The following is a description of a gene set: Catalysis of an oxidation-reduction (redox) reaction in which hydrogen or electrons are transferred from NADH or NADPH and one other donor, and one atom of oxygen is incorporated into one donor. species: Homo sapiens Human Gene Set: GOMF_OXIDOREDUCTASE_ACTIVITY_ACTING_ON_PAIRED_DONORS_WITH_INCORPORATION_OR_REDUCTION_OF_MOLECULAR_OXYGEN_NAD_P_H_AS_ONE_DONOR_AND_INCORPORATION_OF_ONE_ATOM_OF_OXYGEN, and this is the list of marker genes: CYP3A4, CYP4X1, NOS3, CYP27B1, COQ6, AKR1C1, CYP1B1, AKR1C3, NOS2, FMO1, CYP51A1, ESR1, HSP90AA1, CYP26B1, CYP46A1, COQ7, FMO5, NOS1, MICAL3, MICAL1, CYP4F2, KMO, CYP2D6, ATP2B4, MICAL2, AKT1, CYP4V2, AKR1D1, NOS1AP, FMO4, CALM3, FMO2, CYP4F11, CYP1A1 (cytochrome P450 family 1 subfamily A member 1), CYP26A1, CAV1, CYP2E1, AKR1C2, AKR1C4, ACTB, CYP2B6, HSP90AB1, SQLE, FMO3, DYNLL1